The following is a description of a gene set: species: Mus musculus Mouse Gene Set: GOBP_SPHINGOLIPID_CATABOLIC_PROCESS The chemical reactions and pathways resulting in the breakdown of sphingolipids, any of a class of lipids containing the long-chain amine diol sphingosine or a closely related base (a sphingoid)., and this is the list of marker genes: Lct, Neu1, Hexa, Etnppl, Smpdl3b, Gm2a, Prkcd, Acer1, Cel, Acer3, Enpp2, Smpd5, Vps54, Galc, Asah2, Hexb, Acer2, Smpd3, Gba2, Smpd4, Smpd2, Psap, Neu2, Gba1, Smpd1, Asah1, Neu4, Gla, Sgpl1, Neu3, Glb1, Smpdl3a (NCBI Gene Id 70336), Enpp7